The following is a description of a gene set: Synthesis of diphthamide-EEF2 species: Homo sapiens Human Gene Set: REACTOME_SYNTHESIS_OF_DIPHTHAMIDE_EEF2, and this is the list of marker genes: DPH7, DPH2, DPH6, DPH5, DPH1, DPH3, DNAJC24, EEF2